Given this list of marker genes FCMR, ITPR2, ADD3, ZNF337, NR3C1, POLR2L, IL11, NECAB3, ABHD8, RAD51, IL21R, MGRN1, GLE1, CXCL3, DNAJC1, CDKN2D (NCBI Gene Id 1032), ZNF532, CXCL2, WNT6, ACSL1 (acyl-CoA synthetase long chain family member 1), HELZ, RETREG1, NEO1, LLGL2, ALOX5, NEBL, PLCXD1, CCN2, CCND3, SULT1A2, HMCES, DGKA, NSD2, PALM, CPT1A (NCBI Gene Id 1374), MSI1, DVL3, RALGDS, ACOX2, KIAA0513, TSHR, SLIT2, CDK2AP2, TCAF1, MED12, COL15A1, ARMC9, ACACB, SEPTIN10, TAX1BP3, HMGB1, GABBR2, ENSG00000310521, CAP2 (cyclase associated actin cytoskeleton regulatory protein 2), PDGFRL, CYP4F3, CELSR2, ZNF701, SEMA3B, DNAJB2, RNFT2, GTF2A1, GPER1, SCAMP5, SERPINA1, SNTB2, CC2D1A, DMC1, EI24, ATP2A3, NEMP1, CACNA1G, OLFML2A, MICAL1, PIDD1, STARD3, KIF5C (kinesin family member 5C), B3GAT3, RNASE4, KHK, TRPC1, PRKAB1 (protein kinase AMP-activated non-catalytic subunit beta 1), DIAPH1, BIN1, CCDC85C, NFATC2IP, PARD3, DHTKD1, PASK, ABCA5, HSPB1, GNA11, CAMK2G, IL1RN, FARS2 (NCBI Gene Id 10667), B4GALT4, RRAGD, LRP6, CDK2, PEG10, KCTD9, VAMP2, CCDC92, CPSF4, TFCP2L1, IL17B, MXD1, PDLIM7, here is a description of the gene set: Human Gene Set: AMBROSINI_FLAVOPIRIDOL_TREATMENT_TP53 Genes down-regulated by flavopiridol in the HCT116 cells (colon cancer) depending on their TP53 status: wild-type vs loss of the gene's function (LOF). species: Homo sapiens The results of a phase I clinical trial of the topoisomerase I (Topo I) poison CPT-11 followed by the cyclin-dependent kinase inhibitor flavopiridol in patients with advanced solid tumors indicate that patients whose tumors were wild-type, but not mutant, for p53 obtained the most clinical benefit from this combination therapy. We elected to elucidate the mechanistic basis for this effect in isogenic-paired HCT116 colon cancer cells that were either wild-type (+/+) or null (-/-) for p53. With the combination therapy of SN-38 (the active metabolite of CPT-11) followed by flavopiridol, the induction of apoptosis was 5-fold greater in the p53+/+ cells compared with the p53-/- cells. This sequential treatment induced phosphorylation of p53 at Ser(15), which interacted with Rad51, a DNA repair protein involved in homologous recombination. Rad51 bound to p53-Ser(15) within the first 5 hours of combination therapy, and then was transcriptionally suppressed at 24 hours by flavopiridol only in p53+/+ cells. Microarray analysis also revealed suppression of Rad51 in a p53-dependent manner. Depletion of Rad51 by small interfering RNA (siRNA) sensitized both p53+/+ and p53-/- cells to SN-38-induced apoptosis with increase of gamma H2AX, a marker of DNA damage. Conversely, overexpression of Rad51 rescued p53+/+ cells from SN-->F-induced apoptosis. Because flavopiridol inhibits Cdk9, we found that inhibition of Cdk9 by DRB or by siRNA could recapitulate the flavopiridol effects, with suppression of Rad51 and induction of apoptosis only in p53+/+ cells. In conclusion, after DNA damage by Topo I poisons, flavopiridol targets homologous recombination through a p53-dependent down-regulation of Rad51, resulting in enhancement of apoptosis. from publication Ambrosini G, Seelman SL, Qin LX, Schwartz GK (PMID 18381438)